Given this list of marker genes Tk2, Mgat5b, Tnfrsf11a, Bhlha15, Fam98a (NCBI Gene Id 72722), Nr3c1, Tfdp1, St8sia3, Deptor, Tbx5, Cpne8, Ccdc134, Ttn, Rchy1, Lyrm4, Amotl1, Med13l, Hipk3, Cdin1, Faim2, Cramp1, Oxtr, Specc1, Ap1s3, Kcnj2, Ywhag, Pkp3, Ark2c, 9330159F19Rik, Dhx40, Piga, Runx3, Wfdc13, Igf1r, Rab6b, Lpar3, P2rx7, Usp15, Hsd17b14, Dapk1, Acsm2, Map3k21, Mmp9, Ppargc1a, Mro, Nos1, Pfkp, Wdr37, Aff4, Dok5, Vamp5, Cmtm2b, Atp2b4, Inpp5f, Stc1, Kars1, Hdac9, Zfp280c, Gatad1, Drp2, Dgkk, Sec24c, Plaat1, Ccdc50, Slc1a2, Mmgt1, Fry, Ctnnd1, H2-T15, Lrrc61, Urod, Srd5a3, Cldn11, Eno2, Iars1, Msx2, A130010J15Rik, D430041D05Rik, Pak6, Nr2e1, Sdk1, Sp110, Kcnma1, Zswim6, Dlgap1, Kics2, Bloc1s6, Sult1a1, Setd7, Rc3h2, Slc30a9, Rab2b, Setd1b, Slc16a2, Efna5, Ccl28 (NCBI Gene Id 56838), Il7, Nova2, Agpat5, Sipa1l1, Asap2, Aak1, Tnfrsf21, Cplx3, Kcnk3, Ddr2, Cd46, Epb41l1, Pax1, Phf2, Pdxk, Trim67, Utp23 (NCBI Gene Id 78581), Polr1d, Htr5a, Hnf4g, Frmd3, Prkce, Pcid2, Nhsl2, Cd93, Pnpla3, Rab27b, St6galnac3, Rnf152, Slc47a1, Vangl2, D830030K20Rik, Paqr9, Stard5, Gpd2, AU018091, Gigyf1, Krt2, Rrm2b, Samhd1, Lrp4, Cacng5, Wtap, Cyp4a31, Pramel12, 1700025G04Rik, Zmat3, Dnajc1, Adamts3, Vti1a, Phf24, Lonrf2, Pou3f4, Zgrf1, Slc16a10, Tead1, Ftcd, Agbl2, Zdhhc15, Rnf111, Gnb3, Commd10, Kcnq2, Camk2a (NCBI Gene Id 98128), Arhgap28 (Rho GTPase activating protein 28), Celf1, Iho1, Dnal1, Fgf10, Plekhm3, Kcnj16, Cldn34c1, Astn2, Kcnb1, Asxl1, Exosc1, Ptprk, Suclg2, Zfp169 (zinc finger protein 169), Ssh2, Pard6b, Thrb, Fign, Kcnj15, Ryr2, Gfra2, Casz1, Ifi203, Pla2r1, Zfp248, Zbtb20, Zwint, Lsamp, Tbc1d30, Elmo1, Kif1b, Smyd3, Tacr1, Lyrm7, Sfxn3, Igsf9b, Rora (NCBI Gene Id 319897), Lrrc4c, Scn2a, Kcnc1, Trim5, Gask1b, Srgap3, Tbl2, Smoc1, Otx1, Snx12, Dnm1, Stox2, Nfat5, Hoxb9, Ap3s2, Adam11, Prkcb, Cybrd1, Fam171a1, Efnb3, Pou3f2, Alad, Cyp27b1, Gpr173, Mrc2, 4930579G24Rik, Hectd4, Dnase2a, Pcsk5, B020004C17Rik, Wnt5a, Gng7, Tfap2a, Meis1, Phf21a, Cd36, Kank2, Zbtb34, Kynu, Sp100, Bnip3l, Mylk4, Pakap, Capza2, Ddit4l, Gfra1, Prdm2, CK137956, 2410004P03Rik (RIKEN cDNA 2410004P03 gene), Rsph1, Lzts3, Slc29a3, Ankrd44, Fgf13, Csf2rb2, Ppm1e, Dcdc2a, Rgs20, Gap43, Agl, Gab3, Plk1, 0610030E20Rik, Tagln2, Mob3b, Six3, Myo5a, Adra1b, Slc12a1, Wfdc8, Etnk1, Kcnmb1, Trim12c, Tnrc6b, Dkk1, Vegfa, Ush1g, Neurod6, Krt88, Spire1, Gnaq, Celf4, Kcna2, Zfp799, Slfn14, Pla2g4f, Sdf4, Mtmr2, Zmym3, Gtf3c1, Nat8f2, Cd38, Krt13, Dmbx1, Ndufs4, Gm4841, Ermp1, Nfia, Siglecl2, Ncam1, Slc25a42, Nkx2-3, Slfn5, Thada, Myocd, Tspan18, Acp3, Cyyr1 (NCBI Gene Id 224405), Kctd12, Slc35a5, Hoxd13, Zfp871, Ephb2, Chst3, Sv2c, Taok3, Nono, Gucy1a2, Prr16, Rsbn1, Ncbp3, Eps15l1, Rorb, Pag1, Btg2, Prr18, Impg1, Ppp2r2d, Cd200, Rpp40, Dlc1, Slc4a8, Prlr, Krtap13-1, Dusp7, Mc3r, Kcnq5, Fbxo39, Dcx, Lrp3, St8sia1, Rit2, Septin9, Xiap, Btg1, Lrrc19, Phactr1, Agpat3, Gpr157, Slc16a14, Gadl1, Slc35g3, Zfp583 (zinc finger protein 583), Clec4a3, Ctdspl2, Kctd12b, Rasgrp1, Cdyl2, Uqcc4, Synj2bp, Msrb3, Insm1, Ppp2r1b, Cer1, Qki, Prrx1, Slc7a8, Calcrl, Idi1, Piwil1, Frg1, Fmn2, Map1b, Fgf7, Kcnj10 (NCBI Gene Id 16513), Rpusd2, Repin1, Tmod2, Sypl1, Foxk1, Phlpp2, Nf2, Gltp, Pld2, Nxpe5, Lsm11, Esp16, Limd1, Cflar, Ehf, Ptpn1, Klf3, Tyw3, Car10, Zfp395, Steep1, Gpr45, B3gnt5, Shank2, Fbxl20, Edem1, Hspbap1, Borcs7, Tigit, Glis3, Nipsnap3a, Ap2m1, Zfp780b, Fmo5, Shroom4, Cd59a, Vax1, Zfp706, Armc2, Nfasc, Emx1, Msl3, Sec23a, here is a description of the gene set: from publication Chen Y, Wang X (PMID 31504780) studied in species Mus musculus Genes predicted to be targets of miRBase v22 microRNA mmu_miR_881_5p in miRDB v6.0 with MirTarget v4 prediction scores > 80 (high confidence targets). Mouse Gene Set: MIR_881_5P